The following is a description of a gene set: from publication Cui A, Huang T, Li S, Ma A, Pérez JL, Sander C, Keskin DB, Wu CJ, Fraenkel E, Hacohen N (PMID 38057668) Genes negatively differentially expressed in cell type: CD8+ T cell upon treatment with cytokine: TNF-α in mouse lymph nodes in vivo. Mouse Gene Set: CUI_T_CELL_CD8_TNFA_RESPONSE_DN studied in species Mus musculus Cytokines mediate cell-cell communication in the immune system and represent important therapeutic targets. A myriad of studies have highlighted their central role in immune function, yet we lack a global view of the cellular responses of each immune cell type to each cytokine. To address this gap, the authors created the Immune Dictionary, a compendium of single-cell transcriptomic profiles of more than 17 immune cell types in response to each of 86 cytokines (>1,400 cytokine-cell type combinations) in mouse lymph nodes in vivo. A cytokine-centric view of the dictionary revealed that most cytokines induce highly cell-type-specific responses. For example, the inflammatory cytokine interleukin-1β induces distinct gene programmes in almost every cell type. A cell-type-centric view of the dictionary identified more than 66 cytokine-driven cellular polarization states across immune cell types, including previously uncharacterized states such as an interleukin-18-induced polyfunctional natural killer cell state., and this is the list of marker genes: Rgs10, Cd28, Fxyd5, Lsp1, Selplg, Madd (NCBI Gene Id 353087), Crip1, Hspa1b, S100a10, Adgre5, Emp3, Hcst, Cd3g, Hspa1a, Ypel3, Uba52, Myl6 (NCBI Gene Id 17904), Dnajc15, Tecpr1, Bin2, Actn1, Rasgrp2, Nkg7, Klf6, Atp11b, Klf2, Srgn, Epsti1, Lef1, Klrd1, Smpdl3a, Mbnl1, Mxd4, Thy1 (thymus cell antigen 1, theta), Btg2, Sidt1, Jun, Cd8b1, Crlf3, S1pr1 (sphingosine-1-phosphate receptor 1), Fos, Tent5a, Smc4 (structural maintenance of chromosomes 4)